The following is a description of a gene set: Binding to a long noncoding RNA (lncRNA). Human Gene Set: GOMF_LNCRNA_BINDING species: Homo sapiens, and this is the list of marker genes: STAT3, MIR361, CSDE1, POU1F1, EZH2, DNMT3A, PCBP2, DNMT1, BRD3, PUM2, WDR82, MIR195, CTBP1 (NCBI Gene Id 1487), MIR608, MIR135A1, MIR384, HADHB, SUGT1, MIR665, ATP2A2, RAD21, RBM33, MIR223, MIR29B1, HNRNPU, NONO, KLF4, MIR29A (microRNA 29a), PDIA3, ELAVL1, EEF2, MIR185, PPME1, PPARGC1A, SUZ12